The following is a description of a gene set: Human Gene Set: GOBP_CYTOPLASMIC_TRANSLATIONAL_ELONGATION The successive addition of amino acid residues to a nascent polypeptide chain during protein biosynthesis in the cytoplasm. species: Homo sapiens, and this is the list of marker genes: AARS1, CPEB2, RPLP2, CPEB3, SMYD5, NEMF, EEF1D